The following is a description of a gene set: The process occurring in the embryo by which the anatomical structures of the post-embryonic eye are generated and organized. Mouse Gene Set: GOBP_EMBRYONIC_EYE_MORPHOGENESIS studied in species Mus musculus, and this is the list of marker genes: Arid1a, Foxf2, Bmp7, Fbn1, Cryaa, Twist1, Cited2, Ihh, Tfap2a, Zeb1, Vax2, Sox11, Hipk2, Sp1, Rarg, Kdm2b, Sp3, Six3, Lrp6, Pax6, Mfap5, Th, Frs2, Mfap2, Phactr4, Foxl2, Aldh1a3, Tbx2, Ift172, Prox1, Efemp1, Fbn2, Aldh1a1, Hipk1, Rarb, Fzd5, Stra6, Pax2, Ift122